The following is a description of a gene set: Human Gene Set: REACTOME_G1_S_SPECIFIC_TRANSCRIPTION species: Homo sapiens G1/S-Specific Transcription, and this is the list of marker genes: TK1, LIN52, HDAC1, RBL1, RBBP4, PCNA, RBL2, FBXO5, TFDP1, CDC45, E2F4, CDC25A, TFDP2, CDT1, CDC6, E2F1, E2F5, DHFR, E2F6, CCNE1, CDK1, ORC1, CCNA1, LIN9, LIN37, POLA1, LIN54, TYMS, RRM2